The following is a description of a gene set: Any process that modulates the frequency, rate or extent of the directed movement of iron ions (Fe) into, out of or within a cell, or between cells, by means of some agent such as a transporter or pore. Human Gene Set: GOBP_REGULATION_OF_IRON_ION_TRANSPORT species: Homo sapiens, and this is the list of marker genes: MIR210, B2M, HEPH (NCBI Gene Id 9977), LCN2, IFNG, HAMP, HFE, ISCU